Given this list of marker genes ZNF407-AS1, PTX3, RPE, CHML, ZNF823, PDE4DIP, EPPK1, RFXAP, DCAF8, ZNF250, SMAD5, SKP2, DNAH1, MR1, SMG8, COQ10B, GATM, MAK16 (MAK16 homolog), RIDA (reactive intermediate imine deaminase A homolog), RBM26-AS1, COL27A1, MTAP, CCL28, PLEKHS1, MTMR4, TMPRSS3, PPHLN1, ERI1, VIPAS39, FRMD4B, KRT23, CYRIA, SMUG1, ZSWIM7, NR4A2, CX3CL1, CLCN3, MYO1D (myosin ID), LOXL1-AS1, PMEPA1, GLUD1, GALNT3, LRCH3, USP25, ZYG11B, TRNT1, GABRP (gamma-aminobutyric acid type A receptor subunit pi), ATF3, KRT6B, ACACB, DBR1, AFG2B, PHF20L1, ADNP, PNMA8A, FOSB, ZBTB8A, MAFF, VPS13B, ST3GAL6, EXOSC8, PBLD, MAP4K5, KLF11, PAWR, here is a description of the gene set: Human Gene Set: TURASHVILI_BREAST_NORMAL_DUCTAL_VS_LOBULAR_UP Genes up-regulated in normal ductal and normal lobular breast cells. species: Homo sapiens from publication Turashvili G, Bouchal J, Baumforth K, Wei W, Dziechciarkova M, Ehrmann J, Klein J, Fridman E, Skarda J, Srovnal J, Hajduch M, Murray P, Kolar Z (PMID 17389037) BACKGROUND: Invasive ductal and lobular carcinomas (IDC and ILC) are the most common histological types of breast cancer. Clinical follow-up data and metastatic patterns suggest that the development and progression of these tumors are different. The aim of our study was to identify gene expression profiles of IDC and ILC in relation to normal breast epithelial cells. METHODS: We examined 30 samples (normal ductal and lobular cells from 10 patients, IDC cells from 5 patients, ILC cells from 5 patients) microdissected from cryosections of ten mastectomy specimens from postmenopausal patients. Fifty nanograms of total RNA were amplified and labeled by PCR and in vitro transcription. Samples were analysed upon Affymetrix U133 Plus 2.0 Arrays. The expression of seven differentially expressed genes (CDH1, EMP1, DDR1, DVL1, KRT5, KRT6, KRT17) was verified by immunohistochemistry on tissue microarrays. Expression of ASPN mRNA was validated by in situ hybridization on frozen sections, and CTHRC1, ASPN and COL3A1 were tested by PCR. RESULTS: Using GCOS pairwise comparison algorithm and rank products we have identified 84 named genes common to ILC versus normal cell types, 74 named genes common to IDC versus normal cell types, 78 named genes differentially expressed between normal ductal and lobular cells, and 28 named genes between IDC and ILC. Genes distinguishing between IDC and ILC are involved in epithelial-mesenchymal transition, TGF-beta and Wnt signaling. These changes were present in both tumor types but appeared to be more prominent in ILC. Immunohistochemistry for several novel markers (EMP1, DVL1, DDR1) distinguished large sets of IDC from ILC. CONCLUSION: IDC and ILC can be differentiated both at the gene and protein levels. In this study we report two candidate genes, asporin (ASPN) and collagen triple helix repeat containing 1 (CTHRC1) which might be significant in breast carcinogenesis. Besides E-cadherin, the proteins validated on tissue microarrays (EMP1, DVL1, DDR1) may represent novel immunohistochemical markers helpful in distinguishing between IDC and ILC. Further studies with larger sets of patients are needed to verify the gene expression profiles of various histological types of breast cancer in order to determine molecular subclassifications, prognosis and the optimum treatment strategies.